Given this list of marker genes Il1b, Mcl1, Clec4e, Cxcr4 (C-X-C motif chemokine receptor 4), Rgs1, Cyp4f18, Fth1, Grina, Ccl3, Plek, Serpinb2, mt-Rnr2, Cxcl3, Adam8, Cd52, Lilrb4a, Ccl6, G0s2, Msrb1, Thbs1 (thrombospondin 1), Ccl4, Actb (NCBI Gene Id 11476), Csf2rb, Alox5ap, Trib1, Retnlg, Pla2g7, Antxr2, Cxcl2, Srgn, Basp1, Tyrobp, Cebpb, Tmsb4x, Cybb, Coro1a, Slc7a11, Cd24a, Il1rn (interleukin 1 receptor antagonist), Id2, Laptm5, Ccrl2, Vasp, Lilrb4b, Cd9, Tgm2, mt-Rnr1, here is a description of the gene set: Table S2: Representative genes of each cell cluster from publication Zhang L, Long W, Xu W, Chen X, Zhao X, Wu B (PMID 35669188) species: Mus musculus Mouse Gene Set: ZHANG_UTERUS_C10_STROMAL2_RETNLG_HIGH_CELL